The following is a description of a gene set: from publication Chen Y, Wang X (PMID 31504780) Genes predicted to be targets of miRBase v22 microRNA hsa-miR-6880-5p in miRDB v6.0 with MirTarget v4 prediction scores > 80 (high confidence targets). Human Gene Set: MIR6880_5P studied in species Homo sapiens, and this is the list of marker genes: VDR, NARS1 (NCBI Gene Id 9243), CRNKL1, PRRC2B, PURA, GPR158, ACTN1, ZNF175, TMEM151A (transmembrane protein 151A), SNTA1, GRHL1, GFRA3, GINS1, LHPP, HEYL, ARMCX3, SDK2, JMJD8, USP3, CCNE1, YPEL5 (NCBI Gene Id 51646), PTK6, NTM, ELK4, NFASC, RTN4RL1, COG6, PXK, ELOVL4, MTCL2 (NCBI Gene Id 90072), SHISA7, PLXNA4, GPIHBP1, SCUBE3, LYPD5, FKBP1A, MCCC1, RABL3, PACSIN1, HOXA9, MTF2, POU2F3, GARIN1A, EFNA5, ESRP1, PDGFB, TTC23, KHDRBS3, KLHL21, TRAF3, PATZ1, RAC3, UBE2V1, NDST3, NCMAP, MPV17L, TBX19, GABRR1, RNF8, PHF8 (NCBI Gene Id 57793), SPINK5, IFIT2, OR2H1, SLC35F1, ZNF704, TPCN1, TAP2, DENND2C, SGMS2, AIM2, HDAC2, SPATA12, NCOA2, PDLIM7 (PDZ and LIM domain 7), SH2B3, CES3, C1orf116, CCDC175 (NCBI Gene Id 730656), HPCAL1, KNCN, TBATA, MXD3, CYP3A7, RASGRF2, PEDS1-UBE2V1, XPR1 (NCBI Gene Id 9213), SLC25A35, IFIT1, TYK2, LMO1, CCNJL, ADAMTS9, GRIN2D, SEPTIN3